Given this list of marker genes ADRA1A, ADRA1D, ADRA2C, ADRA2A, ADRA2B, ADRA1B, here is a description of the gene set: Combining with epinephrine or norepinephrine to initiate a change in cell activity via activation of a G protein, with pharmacological characteristics of alpha-adrenergic receptors. studied in species Homo sapiens Human Gene Set: GOMF_ALPHA_ADRENERGIC_RECEPTOR_ACTIVITY